Given this list of marker genes WBP1, CPT1A, MT2A, PSMD8, H4C9, WDR89, CSNK1G1, RRM2, RYR1, NUPR1, GIPC1, NUSAP1, CDC42, here is a description of the gene set: from publication Caffarel MM, Moreno-Bueno G, Cerutti C, Palacios J, Guzman M, Mechta-Grigoriou F, Sanchez C (PMID 18454173) Human Gene Set: CAFFAREL_RESPONSE_TO_THC_24HR_3_DN It has been recently shown that cannabinoids, the active components of marijuana and their derivatives, inhibit cell cycle progression of human breast cancer cells. Here we studied the mechanism of Delta(9)-tetrahydrocannabinol (THC) antiproliferative action in these cells, and show that it involves the modulation of JunD, a member of the AP-1 transcription factor family. THC activates JunD both by upregulating gene expression and by translocating the protein to the nuclear compartment, and these events are accompanied by a decrease in cell proliferation. Of interest, neither JunD activation nor proliferation inhibition was observed in human non-tumour mammary epithelial cells exposed to THC. We confirmed the importance of JunD in THC action by RNA interference and genetic ablation. Thus, in both JunD-silenced human breast cancer cells and JunD knockout mice-derived immortalized fibroblasts, the antiproliferative effect exerted by THC was significantly diminished. Gene array and siRNA experiments support that the cyclin-dependent kinase inhibitor p27 and the tumour suppressor gene testin are candidate JunD targets in cannabinoid action. In addition, our data suggest that the stress-regulated protein p8 participates in THC antiproliferative action in a JunD-independent manner. In summary, this is the first report showing not only that cannabinoids regulate JunD but, more generally, that JunD activation reduces the proliferation of cancer cells, which points to a new target to inhibit breast cancer progression. species: Homo sapiens Genes down-regulated in EVSA-T cells (breast cancer) after treatment with 3 micromolar THC (delta-9-tetrahydrocannabinol) for 24 h.